Given this list of marker genes PCGF2, COL1A2, CHRNA7, EXOC2, HIRA, AGL, COG6, SPEN, CPT2, PHF21A, RFX7, ATN1, KANSL1 (KAT8 regulatory NSL complex subunit 1), ECE1, POR, ASNS, POC1A, PACS1 (NCBI Gene Id 55690), TRRAP, PRKACA, BPTF, SMARCA4, AP4B1, TBL1XR1, FANCL, PIGL, QRICH1, KIF11, FAM149B1, RYR1, SMPD4, POU4F1, DPYD, CENPJ, SNRPN, ZMPSTE24, KCNJ5, DDX3X, RAB3GAP1, XRCC4, PTCH1, COL18A1, PRKACB, FREM1, H4C5, SOX5, CSF1R, SMARCC2, METTL5, MED13L, FMR1, SCNM1, MED12L, COG4, PRMT7, ELN, CLCN3, GJA5, JARID2, WAC, FOXP1, AIFM1, MPDZ, MRAS (muscle RAS oncogene homolog), COMT (NCBI Gene Id 1312), MTX2, EBP, MESD, TGIF1, RNU4ATAC, DLX4, DOCK6, RHOBTB2, SMARCE1, FRA10AC1 (NCBI Gene Id 57208), UNC80, KDM5B, PIGW, TCF20, TBX4, FLCN, KCNK9, SPRTN, ACTG1, KDM3B, ESS2, CIT, JAG1, YY1, EPG5, DGCR2, EIF2S3, H4C3, ABCA5, ACTL6B, PPP2CA, PHIP, MAN1B1, AHDC1, RAP1GDS1, CNTNAP2, TBC1D23, TWIST2, SMS, AGO1, ABCC9, TMEM231, FRMPD4, POGZ, FLNA, SOX11, ZFX, TBCK (NCBI Gene Id 93627), ODC1, PAX3, ASXL3, MYO18B, MUSK, PIK3CD (phosphatidylinositol-4,5-bisphosphate 3-kinase catalytic subunit delta), ATP6V1A, UBAP2L, TRIO, GP1BB, CDC42BPB, SPTBN1, COL11A2, HDAC4, TONSL, ARVCF, ARID1A, KNSTRN, RPS6KA3, EXOSC2, CDK19, PHF8, MMP2, SIM1, CILK1, SPOP, HK1, MAPKAPK5, SETD5, PYCR2, OFD1, GPAA1, SMC3, PTPRF, TRAF7, AUTS2, CPLX1, TBX1, FBXO11, SC5D, TOMM7, CUL4B, PIGO, MBD5, TBX2, ATP6V1E1, STAG2, CCNQ, AP4S1, CDC42, NANS, FZD2, PRIM1, KCNH1, WDR26, PGM2L1, HS2ST1, HDAC8, DYRK1A, BICRA, LTBP1, MYT1L, SIN3A (NCBI Gene Id 25942), KIF7, SIX2, SCAF4, CTNNB1, KCNJ2, TFAP2A, SRD5A3, LAS1L, EDEM3, EBF3, MAP3K7, ZNF462, KDM5A, TOPORS, ARID1B, KDM4B, MED25, USP9X, CDK10, DGCR8, SMARCD1, NXN, TBC1D24, GLI2, SMARCAL1, CASK, ZMYM2, EFNB1, SMG8, KIAA0753, MLXIPL, ACTB, ZNF292, FBXO31, SMC5, KDM1A, RAB3GAP2, CPLANE1, LTBP3, FLNB, SMG9, ADAMTS18, NKX6-2, ZEB2, BCL11A, PUF60, TRPM3, NSD1, CLPB, TOE1, CUL7, SNX14, SYT1, RERE (arginine-glutamic acid dipeptide repeats), ALDH1A2, TLK2, EXT2, SMARCA2, MCTP2, SLC25A46, ALX4, SUPT16H, TRPS1, RNU4-2, PPP3CA, SEC24C, LMNA, IGF1R, TFAP2B, COLEC11, WDR62, KATNB1, PIGQ, MYCN, SMARCB1, KMT2A, ARID2, KAT6B, INTS1, AP4E1, LRP2, SOX4, TCTN3, HSPA9, CASP2, AFF3, CLP1, DOCK7, ZSWIM6, NAA10, SHANK3, CCNK, SNIP1, SET, ALDH6A1, TPR, SATB2, CCDC47, GATAD2B, SH3PXD2B, RAD21, ATP6V1B2, KMT2D, SLX4, FBN1, KMT2B, EFEMP2, KPTN, SETD2, IDUA, RNF135, KAT5, ECEL1, EIF5A, KIFBP, RAP1B, FBXL3, LMX1B, CEP55, CEP57, TGFB3, HUWE1, ALX3, TAF1, STXBP1, EXTL3, PRKAR1B, SETBP1, BCOR, PGAP2, WASHC4, PDE4D, SRCAP, EXT1, PDE6D, RARB, TMEM216, CLIC2, ADNP, ALG3, CAPRIN1, AP4M1, ZBTB20, PRKAR1A, CTCF, CDK13, ATRX, SLC35C1, C2CD3, PGAP3, KAT6A, UFD1, SRRM2, MADD, KCNN3, FOXG1, GLB1, APC, CAMTA1, DPF2, ARSL, OBSL1, JMJD1C, FBXO28, PIGV, PORCN, GJA8, CDH11, TCF4, TP63, ASXL2, HRAS, KDM6A, NEK1, MAB21L1, CCDC8, HNRNPK, RREB1, BBS2, DGCR6, RUSC2 (RUN and SH3 domain containing 2), ATP6V0A2, TWIST1, CHD5, MED12, KCNJ6, HECW2, NACC1, MYMK, KIF15, BRAF, NHEJ1, CUX1, NIPBL, ESAM, MIPEP, PQBP1, DYNC1I2, TUBGCP2, RBMX, PIGY (phosphatidylinositol glycan anchor biosynthesis class Y), SCYL2, PYCR1, CSGALNACT1, PURA, NRAS, here is a description of the gene set: studied in species Homo sapiens Human Gene Set: HP_ABNORMAL_NASAL_TIP_MORPHOLOGY An abnormality of the nasal tip. Abnormal nasal tip morphology